Given this list of marker genes Scnn1b, Aifm1, Edn1, Scnn1a, Ace, Sgk1, Npas4, Scnn1g, Gper1, Nr3c2, Foxo3, here is a description of the gene set: Mouse Gene Set: GOBP_CELLULAR_RESPONSE_TO_MINERALOCORTICOID_STIMULUS studied in species Mus musculus Any process that results in a change in state or activity of a cell (in terms of movement, secretion, enzyme production, gene expression, etc.) as a result of a mineralocorticoid stimulus. Mineralocorticoids are hormonal C21 corticosteroids synthesized from cholesterol and characterized by their similarity to aldosterone. Mineralocorticoids act primarily on water and electrolyte balance.